Given this list of marker genes GLP2R, GNB1, GHRHR, GNG8, GNG3, VIP, GNG4, GNB3, GNG13 (NCBI Gene Id 51764), GCG, GNG12, GCGR, VIPR1, VIPR2, GHRH, GNG5, GNG10, GNG7, GNG11, GNB4, GNG2, GLP1R, GNB2 (NCBI Gene Id 96628), SCTR, GNGT1, ADCYAP1R1, GNGT2, GIPR, GNB5, GNAS, ADCYAP1, GIP, SCT (NCBI Gene Id 6343), here is a description of the gene set: Glucagon-type ligand receptors Human Gene Set: REACTOME_GLUCAGON_TYPE_LIGAND_RECEPTORS species: Homo sapiens